The following is a description of a gene set: Reactome Pathway: Formation of the cornified envelope electronically inferred by orthology from the curated human pathway part of: Keratinization species: Mus musculus This event has been computationally inferred from an event that has been demonstrated in another species.<p>The inference is based on the homology mapping from PANTHER. Briefly, reactions for which all involved PhysicalEntities (in input, output and catalyst) have a mapped orthologue/paralogue (for complexes at least 75% of components must have a mapping) are inferred to the other species., and this is the list of marker genes: Krt32, Cela2a, Klk14, Dsg3, Krt77, Klk12, Krt18, Dsg4, Krt87, Krt35, Krt84, Gm5414, Krt24, Krt13, Krt36, Krt4, Krt26, Lipm, Krt80, Rptn, Krt31, Klk5, Krt33a, Krt19, Krt73, Krt71, Dsc2 (desmocollin 2), Krt76, Stfa2l1, Krt27, Lipn, Dsg1a, Casp14, Stfa2, Krt17, Krt8, Krt86, Ppl, Krt83, Krt15, Lipk, Krt25, Krt14, Cdsn, Spink6, Krt40, Spink5, Krt79, Krt82, Krt28, Krt20, Klk8, Kazn, Krt39, Sprr3, Krt23, Evpl, Jup, Krt33b (NCBI Gene Id 16671), Krt16, Tchh, Krt81